The following is a description of a gene set: studied in species Homo sapiens from publication Wirth TC, Xue HH, Rai D, Sabel JT, Bair T, Harty JT, Badovinac VP (PMID 20619696) Human Gene Set: GSE21360_NAIVE_VS_SECONDARY_MEMORY_CD8_TCELL_UP The transcriptome of naive OT-I T cells was compared to memory CD8 T cells after 1, 2, 3, or 4 infection with ovalbumin expressing Listeria monocytogenes (LM-OVA). Genes up-regulated in CD8 T cells: naïve versus 2' memory., and this is the list of marker genes: TGFBI, RAPGEF2, CDC42EP2, ETV5 (ETS variant transcription factor 5), MYO1B, ZC3H12A, TM4SF5, SPN, TRAF1, SH2B2, TNFRSF10B, HK2, EDNRB (endothelin receptor type B), ADGRG6, NXPE3, GPD2, SLC11A2, KCTD12, ABCA1, FLNB, SPIC, KCNA3, VEGFA, DCSTAMP (NCBI Gene Id 81501), CH25H, PIK3CG, CCL5, CD40, PPP1R3B, SLC39A13, LRRC25, SEMA4C, AOAH, TNF, NFKBIA (NFKB inhibitor alpha), TARM1, SLC2A1, PDPN, EPHA4, VASP, ITGA8, GSAP, CD79A, PGAM1 (NCBI Gene Id 95038), GSR, DTX2, PID1, ITGA5, CHI3L1, IGF2BP2, SLC39A1, LPCAT2, AHR, SLC25A10, GMFG (NCBI Gene Id 9535), PPIC, MET, IRAK3, MALT1, MARCKSL1, HEG1, FCRL5, SLC39A14, DRAM1, DST, PDE10A, MMP14, LMO4, MLLT6, ABCC1, ALKBH5, LRRC8C (leucine rich repeat containing 8 VRAC subunit C), RAB30, CSF3, SH3BP5, DSC1, MICALL2, POU2AF1, IGFBP7, RAPGEF5, TRAF3IP2, PECAM1, EGLN1, SLC1A2, ELL2, IFITM2, PIK3R5, PRELID1, ADK, NFKBIE, BLK, IER3, TES, SAMSN1, DNMT3L, DGAT2, SRC, VCL, ZDHHC6, PPFIBP2, ANTXR1, ADAMDEC1, NOS2, IFT57, ETS1, BCL3, NFKB1, PPP1R14B, FCMR, HCLS1, CYBB (NCBI Gene Id 1536), BYSL, SEMA4A, SCARF1, CLCN7, MRPL52, QSOX1, GPR85, RAB11FIP1, RTN2, EVA1B, PEG10, UFSP2, LAMA2, GNG12, NFIL3, HCK, DUSP16, DCBLD2, SH3BGRL, PDE4B, MYD88, IL12B, DGKH, CMAHP, PRKAR2B, TMEM26, SLCO3A1, FAS, VCAN, FHL3, SLC13A3, RELT, PTPN1, PFKL (NCBI Gene Id 5211), TPI1, GPR18, CEBPB, SLC31A2, SYCE2, MEFV, CXCL1, EAF1, PIK3R6, SDC4, N4BP1, JMJD6, HERPUD1, CEMIP2, RAB20, ARHGAP31, GADD45B, FCGR2B, ME1, IL1RN, FAM114A1, TMSB4X, CP, MIF, GALNT2, TUBB4B, SIK1, KLF7, LPP, HCAR2, CD302, SOD2, MIR155, RRAS, PGM2, C3, FBXL5, DENR